Given this list of marker genes SMAD5, HIP1, NFYB, TIGAR, OGFRL1, MRNIP, CREBRF (CREB3 regulatory factor), TOR1AIP1, WDR33, TMEM256 (NCBI Gene Id 254863), TRIM25, CHRAC1, RPS6KA4, FBXO15, TMEM263, CSHL1, FAM118A, TSPOAP1, RNFT2, STT3B, KCNG3, PCLAF, SZRD1, TAF5, PLTP, TNS3, CIAO2B, FYTTD1, CHCHD1, KLHL2, ALG2, LUZP1, F12 (NCBI Gene Id 58992), CREG1, GCNT1, COLGALT1, STK26, ADARB1, BLTP3A (bridge-like lipid transfer protein family member 3A), GXYLT1, NPTX1, ARHGAP17, SLC43A1, FOXD2, FAM241A, SKP2, JKAMP, PNISR, ROBO1, TFPT, TNFRSF21, MTHFD2L, ABCG2, UBXN2B, GNG5, DGKI, N4BP2, PAX8-AS1, LRRC58, ATP13A3, C1QA, SUSD1, KLHL14, ZNF75D, RNGTT, H2BC4, LYRM4, KIAA1958, CHP1, SPRY2, CXCL2, SLC16A14, ELP6, CCDC127, GNG3, E2F4 (NCBI Gene Id 1874), RGS22, COX5A, GLRX5, ZNF385C, UBE2G1, DOK7, SEC22A, DUOXA2, SENP5, ITGAM, CFD, BTBD3, H2BC6, ADD1, IGSF21, ZMIZ1, TMEM170B, GPRC5A, ELOVL7, PPP1CC, EXOSC5, EXT1, SPRING1, LHFPL2, PAXBP1, PTPRE, GUCY1A1, TYMS, WASF1, IGLJ3, ENOX1, MT1F, BAD (NCBI Gene Id 572), CKS2, RELL1, CD86, CMTM7, MYB (MYB proto-oncogene, transcription factor), KIR2DL4, MAGED1, TAS2R19, PTEN, UBE2H, ZNF608, HHIP-AS1, KANK2, MS4A1, SLC38A9, NPY, CDCA7, CFAP263, RAP1GAP2, PAXIP1-DT, TMSB15B-AS1, NLRP3, SYNCRIP, DEFB114, SH3PXD2A, AAK1, CRYM, SSBP2, ELOB, ADGRL1, KIF2A, CUL4B, CD24, ZBTB10, SMIM7, ZNF880, TMEM178A, MIA2 (MIA SH3 domain ER export factor 2), PIK3CD, ITPRIP, LINC02603, SSBP3, MAGEH1, MPHOSPH9, FKBPL, CORO2B, MELK, ANKRD10, ARHGEF9, FUCA1, PIP5K1B, GTPBP4, KLF8, AKNAD1, H2AC6, TXNDC15, FILIP1L, HNRNPA2B1, MZF1-AS1, POLD1, GNB4, RCBTB1, LILRA2, MGAT4A, AMN1, ID2, UGT2A3, TOP1, ODF2, MAPK8, DAZL, EPS15, PARP1, SH2D3C, ETS2, VAPA, BEX3, CAP2, MBNL2, FCRLA, APCDD1, STK39, PTH2, here is a description of the gene set: Genes down-regulated in CD11b BoneMarrow from BALBc mouse versus CD11b BoneMarrow from BALBc mouse incubated with GMCSF and GCSF. studied in species Homo sapiens from publication Marigo I, Bosio E, Solito S, Mesa C, Fernandez A, Dolcetti L, Ugel S, Sonda N, Bicciato S, Falisi E, Calabrese F, Basso G, Zanovello P, Cozzi E, Mandruzzato S, Bronte V (PMID 20605485) Human Gene Set: GSE21927_UNTREATED_VS_GMCSF_GCSF_TREATED_BONE_MARROW_DN Tumor growth is associated with a profound alteration of myelopoiesis, leading to recruitment of immunosuppressive cells known as myeloid-derived suppressor cells (MDSCs). Analyzing the cytokines affecting myelo-monocytic differentiation produced by various experimental tumors, we found that GM-CSF, G-CSF, and IL-6 allowed a rapid generation of MDSCs from precursors present in mouse and human bone marrow (BM). BM-MDSCs induced by GM-CSF+IL-6 possessed the highest tolerogenic activity, as revealed by the ability to impair the priming of IFN- -producing CD8+ T cells upon in vivo adoptive transfer. Moreover, adoptive transfer of syngeneic, GM-CSF+IL-6-conditioned MDSCs to diabetic mice transplanted with allogeneic pancreatic islets resulted in long term acceptance of the allograft and correction of the diabetic status. Cytokines inducing MDSCs acted on a common molecular pathway. Immunoregulatory activity of both tumor-induced and BM-derived MDSCs was entirely dependent on C/EBP transcription factor, a key component of the emergency myelopoiesis triggered by stress and inflammation. Adoptive transfer of tumor antigen-specific CD8+ T lymphocytes resulted in therapy of established tumors only in mice lacking C/EBP in myeloid compartment. These data unveil another link between inflammation and cancer and identify a novel molecular target to control tumor-induced immune suppression. We used gene expression analysis to identify those factors, secreted by tumor-infiltrating MDSC, which could drive emathopoiesis. Moreover we compare gene expression profile of tumor-induced MDSC, obtained from either the spleen and the tumor infiltrate of tumor bearing mice, and in vitro bone marrow-derived MDSC.